The following is a description of a gene set: studied in species Homo sapiens Genes predicted to be targets of miRBase v22 microRNA hsa-miR-4738-3p in miRDB v6.0 with MirTarget v4 prediction scores > 80 (high confidence targets). Human Gene Set: MIR4738_3P from publication Chen Y, Wang X (PMID 31504780), and this is the list of marker genes: NLN, RPGRIP1L, TLR10, ZNF493, NFIL3, ANKRD45, TOX3, CADM1, GPM6B, KAT6A, ZBTB18, NIPSNAP2, ATXN7L3B, FMR1, BTBD1, FOXO6, CKAP2, PHIP, PMS1, AKAP11 (A-kinase anchoring protein 11), CACNA1E, TIGD6, GNG12, GPX5, TC2N, NCOA2, HOMER1, KIF5C, RPSA (ribosomal protein SA), NETO1, KAT7, OOSP2, HAPLN1, ATP6V1A, SAMD13, SLC17A7, SLC6A15, AFF2, COPS7B, C8orf88, ATP2B4, CTBP2 (C-terminal binding protein 2), FMO5, SPECC1, USB1, SPP2, EIF4G3, PCBP2, PUM2, SIAH1, STXBP5L, DNAJA2, PHF1, OSER1, PBX1, XKR6, MAK16, COPG2, SEPTIN6, KDM7A, PDE4B, RAP2C, SNN, URI1, FMN2, SLC25A24, PCMTD1, CHL1 (NCBI Gene Id 10752), PBRM1, CWC27, RBM42, EPN2, PTPRO, RAD21, WDR48 (NCBI Gene Id 57599), ZFYVE27, SNX19, H2AJ, CSTF3 (cleavage stimulation factor subunit 3), PKNOX2, PNKD, FKBP1A, TGFB2, MYNN, HAVCR1, CRPPA, FYB2, SLAIN2, LDLRAD3 (low density lipoprotein receptor class A domain containing 3), SELL, FBXO32, CTNND2, SLC38A2, MCTS1, GPR137C, FRMD8, NDUFAF5, PGM2L1, RYBP, FAM98B, SAMTOR, WAPL, KIF5A, ADRA1A, TNFAIP1, PAG1, CLOCK, LRRTM3, BCAT1, DCLK1, SHISA6, CD300A, SRP72, PARP15, PTAR1, IPO8, GPR88, PTGER3, WASF3, ZNF277, MIB1, ABL2, ETNK1, TRUB1, HNRNPR, HAL, BORCS8, FBXO11 (F-box protein 11), SS18, RNF180, ANO6, KCNJ1 (potassium inwardly rectifying channel subfamily J member 1), HYI, CEP43, MAP2, SOX11, MAPK9, DTWD1, GPR22, YTHDC1, SPG11, UBA2, TSC22D2, PXYLP1, ONECUT2, UNC5C, DNM1L, RBPJ, CTDSPL2, HNRNPH1, CXXC4, MYSM1, GRSF1, PTPRE, RPRD2, ADAMTS6, UGT3A2, PCDH9, SCYL2, GBP4 (NCBI Gene Id 115361), EGF, PPM1E, MKLN1, HAPSTR1, ZNF211, TRPC3, ZMAT3, SPRTN, TAF9B, KHDRBS1, CERT1, MAP4K5, STEAP2 (NCBI Gene Id 50630), TTN, RNF185, CAPRIN1 (NCBI Gene Id 4076), SSBP3, GTPBP10, SESN3, RETREG1, RUNX1